Given this list of marker genes Dip2b, Fcgr2b, Cytip, Ptprc, Pde7a, Cd79b, Klf2, Neat1, Atp6v0b, Rhoq, Fcrla, Lpgat1, Pnrc2, Smim14, Traf3, Samhd1, Fam107b, Nfkb1, Adcy7, Erp29, Btg2, Ublcp1, Ptk2b, Rgs14, Lsp1, Cd72, Gpcpd1, Zfp36, Tmem50b, Ralgps2, H2-M3, Igkc, Casp9, Crybg1, Ms4a1, Rbm39, H2-Q5, Cd74, S1pr1, Fbxo11, Tank, Birc3, Ubp1, Ero1b, Dtx1, Nfkbiz, Tmem71, Tirap, Cd22, Blk, Il4ra, Traf5, Mcl1, Clk1, Tut7, Ube2h, Slc25a53, Ccndbp1, Capn1, Nbr1, Riok3, Akirin1, Gns, Jarid2, Cnr2, Ablim1, Fam3c, Zfp14 (NCBI Gene Id 243906), Gucd1, Atp6ap1, Sat1, Scd1, Lyn, Ly86, Tk2, Iah1, Myl12b, Il10ra, Tsnax, Btg1, Cd2, here is a description of the gene set: Down-regulated genes in the B lymphocyte developmental signature, based on expression profiling of lymphomas from the Emu-myc transgenic mice: the Pre-BI stage. The Emu-myc transgenic mouse has provided a valuable model for the study of B-cell lymphoma. Making use of gene expression analysis and, in particular, expression signatures of cell signaling pathway activation, we now show that several forms of B lymphoma can be identified in the Emu-myc mice associated with time of tumor onset. Furthermore, one form of Emu-myc tumor with pre-B character is shown to resemble human Burkitt lymphoma, whereas others exhibit more differentiated B-cell characteristics and show similarity with human diffuse large B-cell lymphoma in the pattern of gene expression, as well as oncogenic pathway activation. Importantly, we show that signatures of oncogenic pathway activity provide further dissection of the spectrum of diffuse large B-cell lymphoma, identifying a subset of patients who have very poor prognosis and could benefit from more aggressive or novel therapeutic strategies. Taken together, these studies provide insight into the complexity of the oncogenic process and a novel strategy for dissecting the heterogeneity of B lymphoma. from publication Mori S, Rempel RE, Chang JT, Yao G, Lagoo AS, Potti A, Bild A, Nevins JR (PMID 18922927) Mouse Gene Set: MORI_PRE_BI_LYMPHOCYTE_DN species: Mus musculus